The following is a description of a gene set: Mouse Gene Set: MIR_451B studied in species Mus musculus from publication Chen Y, Wang X (PMID 31504780) Genes predicted to be targets of miRBase v22 microRNA mmu_miR_451b in miRDB v6.0 with MirTarget v4 prediction scores > 80 (high confidence targets)., and this is the list of marker genes: Sh3rf3, Mbnl3, Tnip3, Lipe, Zfp595, Nrep, Pou3f2, Ndufa4l2, Slc12a5, Ints3, Chmp7, Plekhm3, Cadm3, Ghr, Heyl, Acrv1, Tmem109, Gpr141b, Treml2, Nf2, Asic4, Ccr7, Ankrd17, Slc6a9, Crocc2, Ccdc121rt2, Smug1, Zhx1, Slit2 (NCBI Gene Id 338531), Clec16a, Trib2, Lhfpl3, Plscr1, Chd8 (chromodomain helicase DNA binding protein 8), Tbl1xr1, Csn1s2b, Cbx6, Polr1a, Hivep3, Fem1c, Ankrd33b, Pias1, Camk1d, Khdrbs2, Rab7b, Cct8, Rassf2, Mbp, Tnrc6b, Astn1, Dcx, Iqsec3, Cybb, Uts2r, Fgfr4, Mtcl2, Fkbp4, Grhl2, Plrg1, Ppard, Ppfibp1, Hs3st2 (NCBI Gene Id 195646), Cnot9, Kctd5, Brme1, Plac8 (NCBI Gene Id 28008), Tacc1, Uqcrq